The following is a description of a gene set: Human Gene Set: GOBP_SULFUR_AMINO_ACID_METABOLIC_PROCESS studied in species Homo sapiens The chemical reactions and pathways involving amino acids containing sulfur, comprising cysteine, homocysteine, methionine and selenocysteine., and this is the list of marker genes: BLMH, CBS, CDO1, FMO1, GNMT, GGT1, ENOPH1, MSRA, SLC7A11, MTR, GCLC, CSAD, ENSG00000274276, APIP, ADI1, BPHL, CPS1, MAT1A, AGXT (NCBI Gene Id 51432), MPST (mercaptopyruvate sulfurtransferase), BHMT, MTRR, MTHFD1, BHMT2, MTHFR, GCLM, CTH, DPEP1, SMS, TST, MMUT, NOX4